Given this list of marker genes Pik3r2, Atp11b, Hmbox1, Rrbp1, Kctd1, Saysd1, Gng7 (guanine nucleotide binding protein (G protein), gamma 7), Stk35, Rspo2, Edem3, Mapkbp1, Ntng1, Ubfd1 (ubiquitin family domain containing 1), Bzw2, Lats2, Kif3b, Bace1, Rock2, Angptl2, Prune2, Sec14l1 (SEC14-like lipid binding 1), Nherf2, Jakmip2, Lmbrd2, Nfxl1, Anxa7, Elk3, Hmgxb3, Hps5, Unc5c, Foxn3, Washc4, Mtmr12 (NCBI Gene Id 268783), Zfp385a (NCBI Gene Id 29813), Zfp951, Rab1b, Prlr, Sptbn1, Nbea, Orc5, Rasal2, Sntb2, Ralgapb, 4930562C15Rik, Aplf, Elovl6, Mob1b, Vps37c, Col4a3, Ywhag, Mfhas1, Ssr1, Tbc1d4, Fgf11, Gsk3b, Entpd4, Manea, Zbtb34, Syt3, Bmper, Cacna1e, Pdp1, Clvs2, Bsn (bassoon), Zfp131, Phldb2, Entpd7, Net1, Pcyt1b, Scn2a, Jade1, Kcnj6, Actr3b, Nedd9, Cplx2, Dap, Ebf1, Rnf138, Pitpnc1, Pde1a, Smim13, Cacna1d, Rbak, Slc9a9, Shisa6, Cdyl2, Kcnab3, Fermt2, Plekhb2, C2cd2, Syne1, Glrb, Cntnap1 (NCBI Gene Id 53321), Arhgap6, Smad5, Rsbn1l, Arel1, Slc16a6, Kcnd1, Ntrk2, Kcnn3, Zbtb44, Pggt1b, Gad1, Naaladl2 (NCBI Gene Id 72682, N-acetylated alpha-linked acidic dipeptidase-like 2), Atp2b3, Kcnb1, Zranb2, Baz1a (NCBI Gene Id 217578), Slc12a6, Jak2, Zdhhc6, Ssr2, Setd7, Kcnq5, Ccsap, Arhgap11a, Creb5, Gpr21, Kalrn, Shisa7, Traf4, Erbb4, Ilrun, Zfp322a, Mbnl1, Trpc6, Ccdc92b, Mtus1, Ppp6r3, Wapl, Kdm1b, Ppp1r12c, Evi5, Slc39a13, Psip1, Ergic2, Sdcbp, Hoxa10, Esrra, Gria3, Wnt3, Col5a1, Hif1an, Bcl11a, Spmip4, Snx18, Tti2, Dpf1, 1600012H06Rik, Tstd2, Arl5a, Klf4, Fbln5, Mastl, Cramp1, Acvr1b, Srsf3, Casz1, Zfp518a, Ado (2-aminoethanethiol dioxygenase), Topors, Slc30a4, Cadm3, Meak7, Spock1, Trim66 (NCBI Gene Id 330627), Trp63, Nr3c2, Kdm5b, Ghsr, Abce1, Ppp2r5c, Cttnbp2, Ubox5, Slco5a1, Ildr2, Chmp4b, Wscd2 (NCBI Gene Id 320916), Ppp1r1c, Bach1, Dram2, Setbp1, Man1a, Mtmr2, Parn, Sema3e, Fcho2, Slc8a1, Sema3a, Dag1, Myocd, Sirt1 (NCBI Gene Id 93759), Atp8a1, Wdr45b, Elovl7, Gabrb2, Chd1, Meltf, Strbp, Garin1b, Runx2, Cplx1, Ints2, Kdm7a, Slfn5, B3glct, Dip2c, Arhgef4, Zfp385b, Syt2, Ncln (NCBI Gene Id 78831), 2310022B05Rik, Zfp654, Lmtk2, Zfp292, Cpd, Camk1g, D630045J12Rik, Taf4, Med13, Pde8b, Foxo1, Zfp831, Slc24a2, Tnpo1, Rnf43, Zcchc14, Mtss1, Chsy1, Sv2b, Arhgef15 (Rho guanine nucleotide exchange factor 15), Vamp2, Wdr33, Rgl1, Mypop, Slc25a5, Atg14, Slc5a7, Thrb, Gulp1, Zfp236, Ndrg4, here is a description of the gene set: Genes predicted to be targets of miRBase v22 microRNA mmu_miR_135b_5p in miRDB v6.0 with MirTarget v4 prediction scores > 80 (high confidence targets). from publication Chen Y, Wang X (PMID 31504780) studied in species Mus musculus Mouse Gene Set: MIR_135B_5P